The following is a description of a gene set: Binding to a phosphate ion. species: Homo sapiens Human Gene Set: GOMF_PHOSPHATE_ION_BINDING, and this is the list of marker genes: MTHFD2, CHST14, ADSS1, G6PC1, RELA, ADSS2, SLC34A2, STAT5A, OTC, RPH3A, PNP, NCEH1, PDE2A